The following is a description of a gene set: from publication Alonso SR, Tracey L, Ortiz P, Pérez-Gómez B, Palacios J, Pollán M, Linares J, Serrano S, Sáez-Castillo AI, Sánchez L, Pajares R, Sánchez-Aguilera A, Artiga MJ, Piris MA, Rodríguez-Peralto JL (PMID 17409456) Metastatic disease is the primary cause of death in cutaneous malignant melanoma (CMM) patients. To understand the mechanisms of CMM metastasis and identify potential predictive markers, we analyzed gene-expression profiles of 34 vertical growth phase melanoma cases using cDNA microarrays. All patients had a minimum follow-up of 36 months. Twenty-one cases developed nodal metastatic disease and 13 did not. Comparison of gene expression profiling of metastatic and nonmetastatic melanoma cases identified genes with a >2-fold differential expression ratio and a false discovery rate of <0.2 (206 up-regulated and 37 down-regulated). This set of genes included molecules involved in cell cycle and apoptosis regulation, epithelial-mesenchymal transition (EMT), signal transduction, nucleic acid binding and transcription, protein synthesis and degradation, metabolism, and a specific group of melanoma- and neural-related proteins. Validation of these expression data in an independent series of melanomas using tissue microarrays confirmed that the expression of a set of proteins included in the EMT group (N-cadherin, osteopontin, and SPARC/osteonectin) were significantly associated with metastasis development. Our results suggest that EMT-related genes contribute to the promotion of the metastatic phenotype in primary CMM by supporting specific adhesive, invasive, and migratory properties. These data give a better understanding of the biology of this aggressive tumor and may provide new prognostic and patient stratification markers in addition to potential therapeutic targets. studied in species Homo sapiens Human Gene Set: ALONSO_METASTASIS_DN Down-regulated genes in melanoma tumors that developed metastatic disease compared to primary melanoma that did not., and this is the list of marker genes: CYP7B1, SECISBP2, EDN2, FOXO1, PCDH9, LFNG, OLIG2, CYP19A1, WNT2, IFI44L, GIMAP6, AKAP13, LINC00906, TCOF1, NTF4, EPS15, REST, TOB2, PAPPA (pappalysin 1), CDH10, RGPD1, LRRC2, BCL2L10 (BCL2 like 10), IDS, PAXX, ACKR2